Given this list of marker genes Tgfb2, Wnt10b, Wnt5a, Msx2, Gal, here is a description of the gene set: species: Mus musculus Mouse Gene Set: GOBP_POSITIVE_REGULATION_OF_HAIR_FOLLICLE_MATURATION Any process that activates or increases the frequency, rate or extent of hair follicle maturation.